The following is a description of a gene set: Human Gene Set: HP_TRANSVERSE_TERMINAL_LIMB_DEFECT studied in species Homo sapiens Transverse terminal limb defect A congenital anomaly that appears as an amputation at different levels of the extremity. The limb is missing the terminal (distal) segment(s), with preservation of all the segment(s) proximal to the missing segment., and this is the list of marker genes: TP63, NEK1, RSPO2, WNT3, SEM1, ARHGAP31, REV3L, EOGT, DOCK6, TBX3, DLX5 (NCBI Gene Id 80275), DLX6, NOTCH1, IKBKG, EPS15L1, TBX5, BTRC (NCBI Gene Id 8945), LMBR1, TBX4, PLXND1, FBXW4, CDH11, RBPJ (recombination signal binding protein for immunoglobulin kappa J region), WNT10B, DLL4